The following is a description of a gene set: Human Gene Set: GOBP_SPINAL_CORD_MOTOR_NEURON_CELL_FATE_SPECIFICATION studied in species Homo sapiens The process in which a cell becomes capable of differentiating autonomously into a motor neuron in an environment that is neutral with respect to the developmental pathway., and this is the list of marker genes: HOXC10, LMO4, MNX1, OLIG3, GLI3, HOXD10, ISL2, SUFU, LHX3, ISL1